The following is a description of a gene set: Mouse Gene Set: TABULA_MURIS_SENIS_HEART_FIBROBLAST_OF_CARDIAC_TISSUE_AGEING from publication Tabula Muris Consortium (PMID 32669714) species: Mus musculus, and this is the list of marker genes: Selenow, Arpc1b, Emc10, Gstm1, Cfl1, Bsg, Aox3, Tmem176a, Mmp3 (matrix metallopeptidase 3), H3f3b, Drap1 (NCBI Gene Id 66556), C1qc, Plp1, Tagln2, Tubb5, Vcam1, Ak1, Adh1, Adamtsl3, Nsg1, Cd82, Spr (sepiapterin reductase), Cd74, Anapc11, Ifitm2, Arhgdib, Npdc1, Lyz2, Sf3b2, Cyb5r3, Rnf181, Pltp, Tmed9, Phf11d, Rplp0, Tex261, Fxyd5, Kdelr1, Snai1, Sdhc, Scn1b, Tm4sf1, Zfp36, Serpina3n, Ptms, Junb, Ubb-ps, Laptm4a, Map1lc3a, Rnf166, Grina, Snrpc, Bcl2l1, H2-Aa, Ybx1, C3, Rbm26, Cirbp, Rpl6, H2-Ab1, Tomm6, Eif5a, Psmb8, Igfbp6, Cxcl1, Akr1a1, Fth1, Nfkbiz, Tmsb10, Mospd3, Txn2, Phlda3, Kdm6b, Egr1, Shisa5, Ces1d, Rrp1, Ahsg, S100a16, Ube2v1, Rpl13a, Szrd1, Capg, H2-D1, Cystm1, Tnfsf12, Elof1, Ccn1, Srsf5, Sf3b4, Myoc, Skil, Rbm3, Sox9, Tubb4b, Dhrs3, Rpl4, Ngf, Cotl1, Efemp1, Rack1, Cltb, Atf3, Gnb1, Lamtor1, Aldoa, Rhoc, Cdkn1c, Gadd45b, Clic1, Bri3, Hsd17b12, Ldhb, Meox1, Ly6a, H2-K1, Rps7, Ssbp4, Apoe, Eif3f, Srsf2, Selenom, Cd151, Tnfaip1, Mafb, Cyba, Npc2, Tkt, Ctsb, Ier3, Penk, Socs3, Slc25a5, B2m, Adrm1, Wbp2, Myc, Vim, Arhgdia, Ptma, Rem1, Fos, Cryab, Olfml3, Fbln7, Cx3cl1, Pla1a, Arl8a, Hes1, Arpc3, Slc25a3, Hsd11b1 (hydroxysteroid 11-beta dehydrogenase 1), Cytl1, Pebp1, Icam1, C4b, Thbd, Lrrc8a, Gpx3, Rpl13, Rras, Il33 (interleukin 33), Ldha, Cygb, C1qa, Ddhd2, Prr13, Apod, Ccn5, Rps3, Nabp2, Ap2s1, Tnfrsf1a, Mid1ip1, Ywhae, Lgmn, Inmt, Gstp1, Cd63, Tmt1a, Gna11, Tcf7l2, Prnp, Tspan4, Gcg, Bcl7c, Fdps, Ftl1, Sumo3, Zfp36l1, Nppa, Gabarapl1, Ier2, Mgst1, Rtp4, Gsta3, Arpc4, Nfic, Rpsa (ribosomal protein SA), Dlgap4, Twf1, C1qb, Oaz1, Ninj1, Crip2, Rnaset2b, Pcolce, Prdx5 (peroxiredoxin 5), Irf1, Jund, Gpnmb, Lgals3bp, Pdlim7, Nr4a1, Gpx4, Fxyd6, Bst2, Id3, Cd9, Cmtm3, Trf, Tle5, Ly6c1, Igfbp7, Pfn1, Lmo4, Ndufa4l2, Tmem176b, Tmem160, H2-T23, Dpysl2